The following is a description of a gene set: Mouse Gene Set: chr4D3 species: Mus musculus, and this is the list of marker genes: Fam131c, Ubxn10, Padi2, Rnf186, Fam43b, Aunip, Pithd1, Fblim1, Spata21, Gm13017, Ncmap, Micos10, Epha8, Klhdc7a, Vwa5b1, Ece1, Il22ra1, Stpg1, Gm30191, C1qc, Mir6403, AB041806, Padi3 (NCBI Gene Id 213071), Aldh4a1, Otud3, Slc30a2, Emc1, Ddost, Hmgn2, Myom3, C1qb, Akr7a5, Pla2g2d, Lypla2, Srarp, Gm25280, Mir700, 1700029M20Rik, Gm26226 (predicted gene, 26226), Cdc42, Ephb2, Zfp683, Atp13a2, Clcnkb (NCBI Gene Id 56365), 1700095J12Rik, Hp1bp3, Tas1r2, Tmem50a, Rcc2, Rpl38-ps1, Mir7018, 4930515B02Rik, Gm13012, Arhgef19, Catsper4, Padi1 (peptidyl arginine deiminase, type I), Usp48 (NCBI Gene Id 72765), Zpld2, Gm12989, Stmn1, Gm12988, Gm13025, Rhd, Szrd1, Gale, Lactbl1, Htr1d, Eloa, Gm13010, Mir2139, 2310026L22Rik, Mir7019, Gm13019 (NCBI Gene Id 638735, predicted gene 13019), Sdhb, Extl1, Nbl1, Wnt4, Gm13021, Zfp46, Necap2, Gm45533, 1700013G24Rik, Cela3a, Gm12984, Zbtb40, Grhl3, Man1c1, Hspe1-ps4, Cnksr1, Eif4g3, Gm13031, Pla2g2a, Slc66a1, Rsrp1, Cela3b, Id3, AI507597, Capzb, Crocc, Gm9867, Fuca1, Gm13005 (NCBI Gene Id 100417686), Gm13001, Zfp593, Gm13056, Cda, Epha2, Clcnka, Pla2g2c, Igsf21, Zbtb17, Gm13047 (predicted gene 13047), Rap1gap, Alpl, Slc25a34, Ubr4, 2810405F17Rik, Ldlrap1, Gm13250, Kif17, Mtfr1l, Gm12987, Gm12986, Zfp593os, Sh2d5 (SH2 domain containing 5), Gm12990, Syf2, Mfap2, Iffo2, Tmco4, Pax7, Lin28a, Cd52, Padi6, Gm12983, Selenon, Pla2g5, Pdik1l, Mir6399, Cplane2, Rpl31-ps10, Sh3bgrl3, Tex46, Gm13016, 4933427I22Rik, Mul1, Hspb7, Gm1667, Pnrc2, Gm13076, Tmem82, Gm16287, Camk2n1, Pla2g2f, Gm13003, Trim63, Gm13007, Ubxn11, Pafah2, Arhgef10l, Maco1, Gm23834, Gm13029, Hnrnpr, Padi4, Rpl11, 1700021N21Rik, Nipal3, Cep85, Kdm1a, Pla2g2e, Mrto4, Rap1gapos, Pink1, C1qa, Gm13075, Rcan3, Spen, Gm13030, Ifnlr1, 6030445D17Rik, Luzp1, Ldlrad2, Gm13032, Hspg2, Fam110d, Mir7020, Dhdds, Clic4, Srrm1, Tcea3, Paqr7, Hmgcl, 4921514A10Rik, Gm16225, Asap3, Srsf10 (NCBI Gene Id 14105), Ccnd3-ps, E2f2, Cnr2, Runx3, Htr6, Fbxo42, C630004L07Rik, Crybg2